The following is a description of a gene set: Mouse Gene Set: GOBP_CELL_MATURATION species: Mus musculus The cellular developmental process, independent of morphogenetic (shape) change, that is required for a specific cell to attain its fully functional state., and this is the list of marker genes: Rb1 (RB transcriptional corepressor 1), Pparg, Ret, Actl6b, Ntn4, Opa1, Kcnip2, Defb1, Rnd1, Ednra, Tdrd1, Epas1, Wee2, Tgfb1, Tssk3, Gdf11, Hoxb13, Klf1, Tusc2, Efcab9, Galnt3, Kdr, Tmprss12, Pla2g10, Cntn2, Cftr, Nrxn1, Tmigd1, Pou2f2, Zbtb7a, Foxa1, Gnaq, Tdrd7, Ythdf2, Tal1, Mir132, Ereg, Esr2, Hdac6, Catspere1, Ccl21a, Gsk3b, Nppc, Epo, Slc26a3, Spinkl, Hes1, Svs3b, G6pd2, Ier3ip1, Epha8, Ccl19, Fgfr1, Bnc1, Kif14, Semg1, B4galt5, Diaph3, Bap1, Septin4, Catsper2, Svs3a, Gm36723, Zar1, Adgrb3, Sirt2, Anks1, Gata2, Neurog2, Il15, Rec8, Akr1b1, Abl2 (NCBI Gene Id 98214), Klf2, C3, Tcp11x2, Pde3a, Mir212, C2cd6, Six3, Catsper4, Dleu2, Washc5, Fam210b (NCBI Gene Id 99270), Cst5, Pcsk4, Gm15915 (predicted gene 15915), App, Bfsp1, Abhd2, Rac1, Hif1a, Cebpa, Ren1, Rps6ka2, Fem1b, Prkaca, Ccnb1, Wdr77, Fzd5, L3mbtl3, Xbp1, Cbfb, Brca2, Maea, Oosp2, Sox8, Tmem79, Tcp11 (t-complex protein 11), Angptl8, Ropn1, Ankle1, Pgr, Slc26a6, Vsx1, Brd1, Slfn14, Hes5, C1ql1, Adam7, Grip2, Ank3, Lrrk2, Ngf, Foxo3, Il21, Spink1, Smim45, Cabyr, Clec7a, Tyms, Kcnb1, Nfix, Bsph1, Grb14, Bloodlinc (NCBI Gene Id 105463053), Scarf1, Sptbn4, Hoxa5, Trip13, Kctd9, Pla2g3, Kcnq2, Farp2, Fbxo41, Gba1, Catsperd, Bcl2, Lcn6, Ercc2, Catspere2, Cspg4, Plcb1, Rxfp2 (relaxin/insulin-like family peptide receptor 2), Rfx3, Pabpc1l, Rac3, Runx3, Hba-x, Rnase9, Ihh, Ropn1l, Ctnnb1, Nrcam, Akap5, Gldn, Cdkn1c, Ascl1, Ednrb, Nfasc, Ppp2r1a, Ccdc39, Defb37, Gpat4, Pdgfb, Bsph2, Sox18, Pth1r, Bfsp2, Aurka, Lsm14b, Ptk2b, Mos, Epb42, Mtor, Cdkn1a, Edn1, Runx1, Nox1, Insl3, Lgi4, Cdc25b, Spg21, Ccr6, Shb, Btk, Cntnap2, Tfcp2l1, Dlg2, Nemp1, Irx5, Dazl, Iqcf1 (NCBI Gene Id 74267), H3f3a, Gja1, Vegfa, Npr2, Dmc1, C1qa, Sox10, Myoc, Slc22a14, Kcnq3, B4galt6, Tut7, Nr4a2, Tdrd5, Heatr3, Srrm4, Tdrkh, Gata3, Axl, Fev, Foxj1, Kdm1a, Dld, Runx2, Tdrd6, Ptbp3, Catsperz, Kcne1 (potassium voltage-gated channel, Isk-related subfamily, member 1), Pmp22, Catsper3, Kcnma1, Ghrhr, Pebp1, G6pdx, Sclt1, Id2, Fam20c, Mecp2, Tut4, Tbx6, Flvcr1 (NCBI Gene Id 670389), Fbxo5, Trim58, Pld6, Mir133b, Map3k13, Rac2, Calca, Catsperb, Bhlha15, Bcl11a, Washc1, Zar1l, Lhx6